Given this list of marker genes Ubtf, Ubtfl1, Taf1b, Cebpa, Taf1c, Smarcb1 (SWI/SNF related, matrix associated, actin dependent regulator of chromatin, subfamily b, member 1), Tbp, Rrn3, here is a description of the gene set: studied in species Mus musculus Mouse Gene Set: GOMF_RNA_POLYMERASE_I_TRANSCRIPTION_REGULATORY_REGION_SEQUENCE_SPECIFIC_DNA_BINDING Binding to a specific sequence of DNA that is part of a regulatory region that controls the transcription of a gene or cistron by RNA polymerase I.